Given this list of marker genes MBD4, CALML4, FGF14, DYM, PTK7, POLR1D, DUSP16, RBPJ, APC, KPNA4, HCCS, CD44, NFE2L2, AFF1, CLPB, ADIPOR1, TNKS2, TENM1, COMMD4, ZC2HC1C, TCP1 (t-complex 1), NR1H3, GCH1, IGDCC3, TFDP1 (transcription factor Dp-1), PPP1R15A, ELK3, ABCF2, AXIN1, IER2, PIAS1, GNPDA1, C1orf174, PRIM2, SON, LMAN2, SLC4A1AP, DR1, SSR2 (NCBI Gene Id 6746), TNNI3, PSMD12, NOS1, AOAH, CSNK1G2, MRPS5, LY86, PRKCH, PPM1B, CACNA1A, POLR2D, SAA1, MUC1, F12, REX1BD, GTF2B, MERTK, VIL1, CXCL2, MAGED1, PPP1R14B, AP3S1, LRP10 (LDL receptor related protein 10), NANS, LY6G6C, DDX18, PDIA3, TNIP1 (NCBI Gene Id 10318), AGFG1, UQCC1, TNF, GGPS1, NAV2, DKK1, SLC25A6, SIRPA, IL6, KRTDAP, HDHD2, COA6, TMEM147, GFER, PLEKHO1, CH25H, MAFF, BATF, RRP1, MAFB, MAP3K5, APLP2, BOLA2, SASH1, GLB1, KLF4, ADAR, RMND5A, BCL7C, SNORA7A, PDCD4, G6PD, IL4R, EVL (Enah/Vasp-like), C1QB, GPR132, CTCF, RAB7A, CEP350, CD300C, FEM1B, CTBP2, PPP4R2, UBL3, MED12L, SMNDC1, GSTT1, TNFAIP8, ZRSR2, GTF2A1, VAV1, IRAG2, RTN1, TRAK1, FAP, BCL2A1, PHF12, DNAAF10 (NCBI Gene Id 116143), PMM2, MC3R, NSUN2, SLC30A1, GCNT1, MSR1, ADRM1, IST1, GPR137B, RPA1, EEF2, PBX2, TINF2, DTD1, TARBP2, AURKA, C1QC, HCK, ATXN10, AQR (aquarius intron-binding spliceosomal factor), CLEC4E, IL4I1, FES, GPN1 (NCBI Gene Id 11321), COPZ1, RPL24, CD72, COTL1, PSME3, SLC35C2, RFK, RPRD1B, EDNRB, CXCL9, STX12, CLPP, RHOJ, UBXN8, ATAD2B, RPS8, SNAPC2, ATP5IF1, GORASP2, NEDD8, TBP, IKZF1, HTR2C, HTATIP2, MDM2, EFNB2, RBM26, GPR162, GALNT11, CDK14, AKR1B15, MOV10, PLXNA2, TUBG2, CD68, CDC34, CITED2, PEX2, SELENOW, GNA13, RHOB, IL1RN, FBXO21, PNPT1, ZFAND2A, AKT2, RECK, PRDX5, TTC27, PMPCB, DLD, here is a description of the gene set: Despite their enormous importance, the molecular circuits that control the differentiation of Th17 cells remain largely unknown. Recent studies have reconstructed regulatory networks in mammalian cells, but have focused on short-term responses and relied on perturbation approaches that cannot be applied to primary T cells. Here, we develop a systematic strategy – combining transcriptional profiling at high temporal resolution, novel computational algorithms, and innovative nanowire-based tools for performing gene perturbations in primary T cells – to derive and experimentally validate a temporal model of the dynamic regulatory network that controls Th17 differentiation. The network is arranged into two self-reinforcing and mutually antagonistic modules that either suppress or promote Th17 differentiation. The two modules contain 12 novel regulators with no previous implication in Th17 differentiation, which may be essential to maintain the appropriate balance of Th17 and other CD4+ T cell subsets. Overall, our study identifies and validates 39 regulatory factors that are embedded within a comprehensive temporal network and identifies novel drug targets and organizational principles for the differentiation of Th17 cells. from publication Yosef N, Shalek AK, Gaublomme JT, Jin H, Lee Y, Awasthi A, Wu C, Karwacz K, Xiao S, Jorgolli M, Gennert D, Satija R, Shakya A, Lu DY, Trombetta JJ, Pillai MR, Ratcliffe PJ, Coleman ML, Bix M, Tantin D, Park H, Kuchroo VK, Regev A (PMID 23467089) species: Homo sapiens Genes up-regulated in CD4 T helper cells Th0: 1h versus 20h. Human Gene Set: GSE43955_1H_VS_20H_ACT_CD4_TCELL_UP